The following is a description of a gene set: species: Homo sapiens Human Gene Set: GOBP_PHASIC_SMOOTH_MUSCLE_CONTRACTION A process in which force is generated within phasic smooth muscle tissue, resulting in a change in muscle geometry. Force generation involves a chemo-mechanical energy conversion step that is carried out by the actin/myosin complex activity, which generates force through ATP hydrolysis. In the phasic smooth muscle, the muscle contraction occurs without an ordered sarcomeric structure. Phasic smooth muscle contraction occurs in a series of discrete contractions and relaxations., and this is the list of marker genes: DRD1, DCANP1, TBX3, HTR2B, DRD2, PTGER3, EDN1, TACR2, GDNF, HTR1D, SCN11A, TIFAB, DLG1 (discs large MAGUK scaffold protein 1), P2RX2, GHRL, EDN2, P2RX3 (NCBI Gene Id 5024), NEUROG1, EDNRB, TBX2, GHSR, EDN3, KIT